The following is a description of a gene set: studied in species Mus musculus Catalysis of the reaction: an N-acylsphing-4-enine + H2O = a fatty acid + sphing-4-enine. Mouse Gene Set: GOMF_N_ACYLSPHINGOSINE_AMIDOHYDROLASE_ACTIVITY, and this is the list of marker genes: Acer2, Acer1, Acer3, Asah2, Naaa (N-acylethanolamine acid amidase), Asah1